Given this list of marker genes Med13, Cp, Ankrd40, Anxa11, Gm19705, Miga1, Fbxw17, 4930592C13Rik, Alcam, Ggt7, Tram1, Cdc37, 2810402E24Rik, E130018N17Rik, Sphk2, Pten, Mtmr10 (NCBI Gene Id 97374), Bscl2, Stmp1, Tmem242, Flrt3, Syvn1, Exosc4, Tbc1d13, Ccnh (NCBI Gene Id 66671), Snx13, Wnk1, Pik3r4, Ppp1cc (NCBI Gene Id 627816), Fbxo36, Bicd1, Smarcd1, 1110004F10Rik, Pbx1, Apmap, 2810454H06Rik, Lamp1, Cpsf3, Ranbp1, Mbnl1, Eif1ad, Zfp524 (NCBI Gene Id 69490), Tor1aip2, Mir8120 (NCBI Gene Id 102465905), Ddx1 (NCBI Gene Id 104721), Ark2n, Tjap1, Mrps18c, Dcaf10, Gm22748, Ehmt2, Ggnbp1, Mysm1, Smc5, Dync1li2, Usp12, Sbno2, Adck5, Gosr2, Tcerg1, Gm11638, Prcc, Snord60, Gm35065, Cep128, 4930432B10Rik, Atp5mc3, Ctbp2, Gm13483, Snap47, BC006965, Scyl3, Iscu, Cops9, Nlgn2, Kdm2b, 4930429F24Rik, Samd13, Wdsub1, Nup188, Rab5if, Prpf3, Rps15, 4933417C20Rik, Gm4876 (NCBI Gene Id 232599), Gm37294, Yy1, Tbc1d31, Snora17, Ing5, Shroom4, Ppm1f, Zfp507, Mrps16, Nfat5, Zfand2a, Mfsd8, Rap1b, Rps20, Afg3l1, Gm14023, Mgme1, Dnai2, Phf7, Meis2, Mtmr2, Arhgef19, Atraid, Sf3a3, Polg, Srp68, Gpatch8, Dolk, Ccng2, Gtf2i, Rnps1, Dct, Rcc1, Gjb2, Mrpl39, Gm17059, Cul4b, Kmt5c, Sav1, Zbtb38, Adrm1, Smndc1, Fdx2, Rpp38, Slc38a2, Rasal2 (NCBI Gene Id 320357), Ccdc103, 1700064H15Rik, Tmbim4, Rbm45, Aamdc, Chchd6 (coiled-coil-helix-coiled-coil-helix domain containing 6), Slc9a1, Bach2os, Cenps, Polr3e (NCBI Gene Id 26939), Sigmar1, Peli1, Cstad, Car6, Tbl1x, Ncbp2, Sf3b4, Taco1, Josd1, Hbs1l, Rad50, Snhg7os, Mbtps2, Rbpj, Galnt10, Rsf1, Ficd, 2310010J17Rik, Chp1, Ep400, Uspl1, Hdgf, Gm15559, Btaf1, Pgap4, Met (met proto-oncogene), Mid1ip1, Pus7, Tfrc, Dnajc5, Nagpa, Traip, Gas7, Rrp8, Mtmr14, Zc3h11a, Myl12b, Gm17690, Kif9, Uba7, Decr1, Hexim2, Mterf1b, Nop2, Gemin5, Ext1, Kifc1, Dclre1a (NCBI Gene Id 80616), Paqr6, Casc3, Hnrnpf, Myo10, Akt2 (thymoma viral proto-oncogene 2), Plin3, Atg2b (autophagy related 2B), Dnttip2, Fzd1, Dok5, Appl2, Fam90a1b, Kansl1, Gabpb1, Sh3gl1, Myl12a, Zmiz1, Psmd6, Isy1, Slc22a23, Snord110, Mcam, Inhca, Med4, Apoe, Gins4, Sae1, Tnpo3 (NCBI Gene Id 97309), Angel1, Eps8, Sirt6, Ccdc137, A930007I19Rik, Ptpa, Hoxb5, Tada1, Map7d1, Psmd3, Wdr3, Mmadhc, Coq7, Sgms1, Tmem268, Tmem97, Dcun1d3, Lrriq3, Ncbp3, Pnck, Lrrc8a, Jmjd4, C130046K22Rik (NCBI Gene Id 399609), Ndufaf1, Rcor1, Rtkn, Ccdc88c, Cep95, Bltp3a, Ubn2, Etnk1, Arhgef2, Zdhhc5, Tpm3, Mrpl27, Rassf3, Cldn12, Zfp770, Dsn1, Ddx47, Man1a2, Gm29337, Adam10, 5430405H02Rik, Usp2, Aloxe3, Unc5b, Slc6a9, Dpy19l4, Ogdhl, 2210016L21Rik, Gm12694, Mapk6, Oaf, Inip, Usf2, Rplp0, Hps4, Rbsn (NCBI Gene Id 78287), Ezr, Dnajc24, Fbxw2, Cmtm5, Fem1b, Tent2, Mrto4, Syne2, Rad9b, Slc35a3, C920006O11Rik, Pum2, Nfkbia, Exd1, Stx8, Fam227b, Alg8, Pigg, Zmym1, Rab7b, Speg, Tchp, Ccar1, Srrt, Entpd2, Inpp1, Naa35, Ccdc83, Cep72, Espn, Btbd19, Mylk3, Oga, Mrps33, Ankrd13a, Ndufs2, Lrrc8d, Nfx1, Sgip1, Znfx1, Fbxl18 (F-box and leucine-rich repeat protein 18), Akt3, Gm13562, Gtf2h2, Rere, Abr, Cks2, Cnbd2, Tpt1, 2310005A03Rik, Itgb1bp1, Zfp560, Tinagl1, Tfeb, Ankra2, Man1a, N6amt1, Rpl7a, 4933433G15Rik (RIKEN cDNA 4933433G15 gene), Gm15441, Gm28818, Kdm1a, Nvl, Mff, Ssbp3, Tut4, Sbno1, Elac2, Elmo2, Snx17, Mir1893, Med26, Foxn2, Celf2, Traf2, Mrnip, Med8, Chn2, Btbd7, Tle3, Sorcs2, Pcna, Idh1, Eid1, Cant1, Yars2, Nhlrc1, Ighmbp2, Twnk, A230083N12Rik, Aurkaip1, Qtrt1, Stk10, Gm5614, Prcp, Dtwd1, Mroh8, Tdp1, C430014B12Rik, Dcaf6, Kif21a, 4930558K02Rik, Fbxo30, Fbxo46, Sf1, Polr3a, 4933434E20Rik, Rab34 (RAB34, member RAS oncogene family), Zeb2, Rhoc, Terf2 (NCBI Gene Id 21750), Wrap53, Snrpb2, Fra10ac1, Zkscan1, Pip4p1, Zmiz1os1, Lrrc8c, Cpt2, Sc5d, Fermt2, Shld1, 1700084C06Rik, Nde1, Ddx11, Trdmt1, Thap1, Slc25a32, Zfp335, Fam149b, Gm4890, Rnf6, Brd2, Hnrnpul1, Mlph, Spring1, Mrrf, 4930589L23Rik, Bzw1, Gm15743, Mpc2, Serinc1, Usp47, Mcoln1, Lrch3, Gpr155, Ube2g1, Rnf187, Sik2, Gapvd1, Ndufs1, Ckap2l, Tmed2, Dhfr, Sncb, Oxld1, Siah2, Col11a2, Dhx16, Zcchc4, Uqcc6, Agtpbp1, Gm10701, Pde1b, Fam20c, Cnot10, Srd5a3, Supt7l, Ap3s1, Mical3, Mrps23, Nsun3, Msh6, Vps36, Mrps2, Cenpu, Bicdl1, Snora73b, Sh3bp5, Pa2g4, Exosc7, Gm20732, H4c1, Vps13d, U2surp, Cbarp, Pabpc1, Mir7688, 4932441J04Rik, Rsbn1, Anln, Gpatch3, Mtmr6, Hnrnpl, Amdhd2, Snrpb, 4930563E18Rik, Arhgef17, Elf1, Disp3, Pcid2, Bnc2 (basonuclin zinc finger protein 2), Copg2, Saal1, Cep83, Nemp1, Dcaf13, Gm7628, Tmem214, Kdm5b, Smad7, Camk2n1, Polr3g, Bltp1, Zfp27, Gm20033, Bsg, Srrm3, Pcbp1, Rad54l2, Rps27l, AI506816, Aga, Tmem30a, Gm2093, Gm25794, Mrpl35 (NCBI Gene Id 66223), Gm829, Pfn1, Cipc, Taok1, Eef1akmt2, Zfp36l2, Kmt2a, Dact1, Pds5a, Tnfaip6, Aip, Dusp12, Gas2l3, Slc7a8, Osgin2, Zc3h6, Gm4285, Rad51ap1, Samhd1, Txndc9 (thioredoxin domain containing 9), Traf7, 4931406C07Rik, Mir7672, Snhg17, Sepsecs, Xylt2, Atp6v1b2, Zfas1, Pold3, Fryl, Comtd1, Gm29083, A930032L01Rik, E130114P18Rik, Arsb, Fpgs, Rbm18, Tpgs2, 9330111N05Rik, Taf4b, Rpl22, Ippk, Itgb3bp, Dhx30, Sat1, Gm12676, Rlf (NCBI Gene Id 77455), Mir3069, Drap1, C1d, Rpl13, Akap11, Ecd, Ddx39b, Gm5129, Zscan12, Ythdc1, Kctd15, Cdc42bpb (CDC42 binding protein kinase beta), Zcwpw2, Rin2 (NCBI Gene Id 99432), Romo1, Casq2, Hps3, Zbed3 (NCBI Gene Id 72114), Pdcd2, 2210408F21Rik, Smarce1, Slx9, Sumf1, Mcm3ap, Rpl21-ps7, Rab2b, Rps14, Extl1, Cherp, Uap1l1, Shf, Adamtsl2, Septin9 (septin 9), Etv6, Atp7a, Atg101, Slc30a9, Nectin3, Naf1, Ap4m1, Cenpw, Klhl21, Cdk4 (cyclin dependent kinase 4), Arl8b, Frs2, Srxn1, Tbp, 2810408A11Rik, Gm14966, Adam12, Hnrnpa2b1, Gm17399, Nhlrc3, Psmd2, Tox4, Aff1, Rnf141, Apod, Acot2, Rxrb, Gm10863, Anapc2, Thrap3, Mterf3, Sema6d, Rnft2, Tyr, Kat2a, Zfp617 (NCBI Gene Id 170938), Avpi1, Cnih4, Abca14, Kdm2a, Repin1, H3c7, 2900052L18Rik, Eps15, Gucd1, Zbtb26, Dguok, Rps3a1, Sdhaf2, 4930412F09Rik, Gm40323, Skic8, Hspa9, Rbm5, Atp5f1d, Marveld1, Hddc3, Snai2, Nhlrc2, Elp2, Gm11840, Taf1d, Tbc1d4, Septin7, Unc5a, Ppm1l, Cnpy4, Gm7008, Rock1, Akirin2, Pkd1, Tspan4, Topbp1, Uhrf2, Ext2, Tirap, Tas1r1 (taste receptor, type 1, member 1), Vgll4, Tnfaip3, Socs3, Bbs2, Nr2c2, 4930447M23Rik, Snx18, Ints10, Cdc42se2, Xpnpep3, Grpel2, Apoo, Mirlet7i, B130034C11Rik, 1110038B12Rik, Ran, Rabep1, Usp43, Sec22b, Scaf8, Pip5k1c, Ctsl, Esyt2, Prr12, Ube2f, Senp8, Ndufs6, Hsd17b12, Gm10655, Clint1, Zfp9, Kctd5, 2810025M15Rik, Eftud2, Rapgef1, Kif15 (NCBI Gene Id 73146), Slc39a7, Vmn1r4, Zfp703 (NCBI Gene Id 353310), Dpp8, Zc3h18, Crebzf, Kcnab1, Ninl, C87436, Slc25a46, Rbm6 (NCBI Gene Id 75102), Lama4, Klf13, Ube2i, Slc35a1, Mllt3, Diaph1, Rpn2, Cdk5rap1, Gsta5, A230001M10Rik, Riox2, Brwd1, Rnf146, Mir6386, Cdkn2c, Ncam1, Lmna, Crem (NCBI Gene Id 12916), Vps18, Ppp4r3b, Srp19, Mrpl19, B3galt5, Wdr26, Fbxw8, 9230114K14Rik, Zfp995, Rabgap1, Top1mt, Mettl1, Pik3ca, Vps72, Ddias, Tipin, Btg1, Gm10433, Taf6, Hira, Col16a1, Lmnb1 (NCBI Gene Id 16906), Fbxo7, Ube2m, Gm12758, Taf10, Rel, Ankrd13c, Eef1akmt3, Fasn (fatty acid synthase), Arsg, Ints6, Rbm26, Ets1, Fam53b, Gm13594, H2az1, Dclk1, Atp1a1, Brcc3, Plcg2 (NCBI Gene Id 234779), 2310057M21Rik (NCBI Gene Id 73180), Resf1 (NCBI Gene Id 77734), Fgd4, Napepld, Nae1, Mrpl44, Caprin2, Zfp868, Bap1, Gm49405, Ccdc85b (NCBI Gene Id 240514), Grwd1, Tedc1, Grcc10, Ing1, Btf3-ps14, Sgms1os1, Ube2k, Emc3, Sde2, Aup1, Ahcyl1, Gm16998, Med6, Sec61bl, Dnajc19, Faxc, Slc25a4, Cry1, Rbl1, Polr2a, Bclaf3, Cdkn2a, Hdac10, Dennd1a, Ccz1, Gm16124, Slc8b1 (solute carrier family 8 (sodium/lithium/calcium exchanger), member B1), Dynlrb1, Eef1b2, Mdn1, Ube3d, Abhd3, Gfm1, Gm23301, Etfa, Proser1, Nt5c3b (5'-nucleotidase, cytosolic IIIB), Tyw1, Atxn2l, Cep120, Ddx46, Cs, Fignl1, Taf9, Inka1, Smc4, Cdc20, Ndrg2, Tmem127, Pcolce2, Gtf3c5, Shb, Smn1, Cnp, Tnfaip8 (NCBI Gene Id 106869), Dym, Cdh19, Dhx15 (DEAH-box helicase 15), Ubiad1, Ugp2, Dgkq, Coa8, Gm23969, Atg16l1, Zkscan8, Nt5c, Rpl26, 1700041I07Rik, Lrrc59, Susd6, Arid1a, Pemt, Snord68, Pcyt1a, Hspd1, Rpl17, Det1, Nfs1, 3110082I17Rik, St13, 9930004E17Rik, Csnk1d, Gjb1, Cpsf1 (NCBI Gene Id 94230), Rad17, Rabggta, Eif3b (NCBI Gene Id 27979), Tex2, Mir8105, Zdhhc3, Deptor, Adgrl3, Mreg, Asf1a, Pgam1, Mat2a, Cdon, Sspn, Ptprf, Alg1, Zfc3h1, Pcbp4, Uggt2, Glrx3, Bag5, Fancd2, Tmem39b, Med22, Kif2c, Pxylp1, Nup54, Ap1ar, Mir7075, Eif2b4, Shoc2, Gm26040, Gm43403, Klc1, Ccno, Tmem101, Prkacb, Telo2, Clk2, Smurf1, Frs3, C2cd2, Eif3g, Tmem248, Fkbp9, Eif4a1, Dync2i1, Efcab7, Hnrnpu (heterogeneous nuclear ribonucleoprotein U), Prdm11, D330041H03Rik, Gm26885, Ppia, Rps19, Qrich1, Wdr75, Amotl2, Bod1l, Bms1, Megf10, Ric1, Ubap2l (NCBI Gene Id 97055), Washc1, Psmc3, Mrpl12, 1810010H24Rik (RIKEN cDNA 1810010H24 gene), Malat1, Nek4, Mrgpre, Fam8a1, 1700003G18Rik, Fig4, Xylt1, Cct8, Fmnl3, Pim3, Fads1 (fatty acid desaturase 1), Agtrap, Sh2b3, Commd10, Saraf, Zfp263, Picalm, P4ha1, P4hb, Snrpd1, Tmem134, Ppp5c, Ndufb7, Egln2, Sem1, Mageb3, Calm2, Neurl4, Ints14, Cfap298, A230056P14Rik, Mcrip1, Acss2 (acyl-CoA synthetase short-chain family member 2), Mdm2, Klhl9, Fnip2, Rab23, Eif3f, Tsfm, Atxn3, Slc35b2, Rnf185, Ndufs7, Rnf145, Agfg1, Plekha8, Etfbkmt, Scaf11, Alkbh2, Polr3b (NCBI Gene Id 97660), Serbp1, Nup205, Faf1, Tcea2, Cxxc4, Tle1, Pakap, Snhg3, Alkbh3, Spa17, Nepro, Vti1b, Sdad1, Gm5847, Snrpd3, Pan3, Msh3, Acox2, Obi1, Rhobtb3, Ifrd1 (interferon-related developmental regulator 1), Mcm8, Gstcd, Mir7668, Dmd, Gas2l1, Tmem199, Cbx3, Bhlhe40, Pigc, Helq, Sart3, Dus1l, Thap2, Trip4, Efcab9, Ipo13, Ppp1r21, Lrp6, Cul5, Tgfbr2, Gm13479, Lman1, Agk, Bloc1s5, Mir100hg, Txnl1, Mul1, Dcakd, Atrnl1, Hapln4, Rbm34, Fiz1, Emc1, Sphk1, Ctsc, Erlin2, Bbs5, Slc6a6, Sys1, Kif5b, Mir8092, Ipo7, Gm13403, Ate1, Frmd6, R3hcc1l, Cryl1, Slc39a6, Trp53inp1, Snx12, Psen1, Zranb1, Ptma, Cdc23, Ctnna3, Kif23, Commd2, Cacybp, Zranb2, Pdia6, Chmp4b, Chd2, Gm20544, Dnajb6, Suds3, Gpr19, Rab31, Ro60, Nab2, Pabir1, Tmem256, Ctdspl2, Slc38a3, Rasal1, Tor1aip1, Mrpl20, Gm7596, Pcyt1b, Cacng2, Nck2, Hoxd3os1, Efcab11, Fosl2, Carmil1, Dyrk1b, Mogat1, Nmnat1, Bcl2, Syt9, Cacna1a, Mtmr9, Ier3, Fen1, Cic, Serpinh1, Bmf, 2610005L07Rik, Tnfrsf19, Rpl18, Zbtb9, Myl9, Psmb1, Gorasp2, Nol9, Moap1, Rgl2, Banf1, Ggnbp2, Sos1, Pgls (6-phosphogluconolactonase), Snord58b, Mrpl3, Gga2, Srcap, Azi2, Rad1, Raf1, Hmgn2, Adamts10, Anxa2, Acy1, Cbx5, Bnip3, Psmg4, Wdr31, Arhgef7, Wdfy1, Abcb9, Zfp607b, Brix1, Raver1, Gipc1, Gm30238 (predicted gene, 30238), Trap1, Gmfb, Laptm4a, Ssx2ip (SSX family member 2 interacting protein), Krcc1, Rimoc1, Slc6a17, Slc39a14, Ankrd24, Ywhaq, Anapc1, Atl2, Atxn7l3, Yif1b, Denr (density-regulated protein), Sgpl1, Eloa, Mto1, Snhg6, Fgfr2, Poldip2, Fbxo5, Rbm15, Tgs1, 1110059G10Rik, D6Wsu163e, Lrrc41, Atxn2, Ppp3ca, 9130604C24Rik, Dglucy, Hes1, Vangl2, Lyset, Gm15867, Itgav, 1700040K01Rik, Mrpl21, Lamtor3, 9530085P06Rik, A130010J15Rik, Ube2j2, Zbtb8os, Junb, Ctdsp1, Mir1938, Ints12, Dusp5, Ddx50, Snx5, Zbtb6, Eme1, Heatr6, Tcf7l1, Naa25, Ttc17, Yeats4, Mindy3, Rpl36, Pggt1b, Mcm7, Rab32, 1500015A07Rik, Ndufv2, Pex3, Trmt6, Pop7, Prkcz, Trmu, Zfp217, Mien1, Cast, Tmem222, Ermp1, Ccdc120, Hprt1, Mitf, AW554918, Garre1, 4930581F22Rik, Mrpl40, Gm16010, Hs1bp3, Eif4e2, Sh3glb1, Mtcp1, Itgb1, Snrpa1, Slc25a22, Myt1, Pafah2, Tmc6, Zfp809, Ddx5, Inca1, Faah, Tpx2, Mrps10, Vps37b, 4930523C07Rik, Zfp24, Setd1a, Slc35c2, Psmg1, Prdm15 (PR domain containing 15), Lzic, Ptgds, Gm37254, Cdiptos, Ropn1l, Ccdc88a, Fam168a, Rps29, B4galt7, Acbd4, Nmd3, Dnlz, Klhl18, Wtap, Zfp882, Tenm4, Fbxl7, Tnip2, Trpv4, AV099323, Sox5, Trib1, Ptpn21, Rnpc3, Zfp518a, Gm16364, C030034I22Rik, Rab26os, Cul4a, Txnip, Gskip, Ccna2, Trim41, Exd2, Eif5b, B230206H07Rik, Ak9, Nup153, Arl8a, Tob2, Prdm4, Utp15, Cmc4, Trmt2a, Rragc, Serf2, Uqcrh, Rbms1, Usp14, Pde12, C630043F03Rik, Lasp1, Angel2, Anp32a, Slc33a1, Zbtb21, Eif2b3, D230022J07Rik, Khdrbs1, Limch1, Gm37885, Emc4 (NCBI Gene Id 68032), Luc7l3, Rny3, Lyrm1, Fcho2, Kmt5b, Gm10797, Cdkn2aipnl, Rnf44, Eno2, Cd63, Abcd3, Slc4a1ap, Spry2, Vac14, Fpgt, Gm26782, Slc5a6, Slbp, 8430429K09Rik, 1600020E01Rik, Vps29, Gm4419, Nelfa, Tomm20, Mtg1, Capn2, Ubqln1, Ccdc107, Ak6, Tgfa, Camk2d (NCBI Gene Id 77170), Hsp90aa1 (NCBI Gene Id 15524), Smarcc2, Ilk, Pcdh7, Senp6, Mir7662 (NCBI Gene Id 102465767), Trip12, Ciao1, Htra2, Gm12762, A930024E05Rik, Tbc1d7, D730003I15Rik, Trpm7, Wdr70, Gm10634, Slmap, Ilf2, Zbtb40, Cbl, Them4, Snora73a, Mfn2, Ubr4, Myh14, Sema6a, Hspe1, Dcdc5, Hipk3, Ift80, Kdm5a, Nfia, Cul2, Nipsnap2, Gdap2, Szt2, Slc25a13, Gm34086, Mm2pr, Bhlhe41, Grk5, Gm24016, Atg12, Wipf2, Exosc3, Chmp3, Rpl21, Clcn6, Ddx20, Rab7 (RAB7, member RAS oncogene family), Gm16208, Atxn7l2, Arl6ip4, Prkab2, Tatdn2, Psmd14, Cops8, Aasdh, Nop56, Gm16853, Map2k5 (NCBI Gene Id 23938), Glrx5, Rfc4, Ddost, Tmsb10, Mir5122, Siae, Gm28777, Oxsm, Calm1, Rpl11, Slc15a4, Calm3, Zfp933, Arid1b, Tmf1, Vhl, Nuf2, Ubash3b (ubiquitin associated and SH3 domain containing, B), Tab3, Snx21, Uggt1, Srpra, Thoc2, Kank4, Ddr1, Ccser2, Ppdpf, Sod2, Birc6, Zfr, Mrpl1, Sptlc1, 5730455P16Rik, 4632415L05Rik, Slc20a1, Nfic, Rpia, Nme1, Dnajc1, Ulk2, Xpo7, Fibp, Gm27003, Cdipt, Pgrmc2, Dffa, Kat6b, Dstyk, 9430007M09Rik, Hint3, Cmc1, Tm9sf1, Vdac2, H3c6, Pitpnc1, Ptov1, Fancc, Mthfr, Nipa2, Wdr1, Rapgef2, C2cd4d, Zfp637, Tsc1, Nus1, Ssna1, Rps17, Noc2l, Gm11205, Pds5b, Vps26c, Edem1, Gne, St3gal4, Ube2v1, Nsmce4a, Zcchc9, Drd1, Klhl10, Gtf2a1, Rbbp8, Gm25744, 1700028E10Rik, Mrpl45, Gm25939, Ttc23, Rbbp4, Ctnnd1, Lamtor5, Pcbp2, Sucla2, Tmem258, Mettl9, G3bp2, Cox19, Nr4a1, Ranbp2, Me1, Fbxo33, Nck1, Abcc5, Hmgb1, Pdcd5, Zfp282, Dut, Sema3b, Sh2b1, Wac, Psma6, Egr1, Spry1, Tomm6, Mblac2, Coro1c, Fam117b, Gas1, Col15a1, Uchl5, Ctso, 1700120B22Rik, Abhd18, Cfap52, Mtf2, Rbm19, Ago2, Mrpl43 (NCBI Gene Id 94067), Rasl2-9, BC004004, Champ1, Smim8, Prdx1, Gm25878, Fam204a, Ddit3, Tfap2a, Zfp36l1, Rdx, Ncbp2as2, Rnaseh1, Wbp4, Vgll3, C2, Cox7a2, Rbm38, Maf, Rbbp6, Ablim3, Capg, Fxyd3, Adam11, Actb, Tmem68, C2cd5, Prkch, here is a description of the gene set: species: Mus musculus Mouse Gene Set: SOX10_TARGET_GENES Genes containing one or more binding sites for (Sox10) in their promoter regions (TSS -1000,+100 bp) as identified by GTRD version 20.06 ChIP-seq harmonization. from publication Yevshin I, Sharipov R, Kolmykov S, Kondrakhin Y, Kolpakov F (PMID 30445619)